The following is a description of a gene set: studied in species Homo sapiens Interosseus muscle atrophy Atrophy of the interosseus muscles (including the palmar interossei that lie on the anterior aspect of the metacarpals, the dorsal interosseus muscles of the hand, which lie between the intercarpals, the plantar interosseus muscles, which lie underneath the metatarsal bones, and the dorsal interossei, which are located between the metatarsal bones. Human Gene Set: HP_INTEROSSEUS_MUSCLE_ATROPHY, and this is the list of marker genes: GARS1, SLC5A6, BSCL2, REEP1, TOR1AIP1